The following is a description of a gene set: Human Gene Set: SP1_01 Genes having at least one occurrence of the motif GGGGCGGGGT in the regions spanning 4 kb centered on their transcription starting sites. This matches the SP1 transcription factor binding site V$SP1_01 (v7.4 TRANSFAC). species: Homo sapiens, and this is the list of marker genes: OLIG2, SERINC2, IDH3G, SLC7A10, KCND2, UBE2Z, ADAM10, BCL3, ANKMY2, LRRC4, UBE2F, DACH1, FBXL19, EPS15, GABARAP, TRPM4, UST (NCBI Gene Id 10090), HYAL2, CRYAB, RAB10, DES, DNMT3A, NSD3, CLPTM1, MAGED1, NDST2, FBRS, UNC13B, YRDC, TPM4, PALS1, SFXN2, CDC42SE1, BAHD1, UNC80, PPP2R3A, GGN, FBXW4, SEC63, PLCD1, ATXN1, GPR3, KPNB1, RPL7 (ribosomal protein L7), GGNBP2 (gametogenetin binding protein 2), NFE2L1, GRIPAP1, TSNAXIP1, HSPB2, EGLN2, STMN1, SLC44A1, NCOA2 (nuclear receptor coactivator 2), PIAS3, POU2F1, HNRNPA2B1, KLF16, VLDLR, NOL4, TAL1, KCNQ4 (NCBI Gene Id 9132), ATAT1, ZNF703, RDH10, FRS3, MEX3B, MYADM, HMGA1, OSBP, BHLHE41, SP4, GGA1, RING1, IRF2BP1 (interferon regulatory factor 2 binding protein 1), MAP3K6, ING2, SIX4, GJB6, EIF5A, RANBP10, GALE, NR2F2 (nuclear receptor subfamily 2 group F member 2), HS2ST1, TADA3 (transcriptional adaptor 3), KANK2, NXPH3, KCNE5, PPFIA2, SPATA6, PLEKHA8, PACS1, FXR2, SSR4, BCL2, CADM1, MARCKSL1, PPP1R21, GBF1 (NCBI Gene Id 8729), MTF1, NUBP2, NKX2-1 (NK2 homeobox 1), REM1, ZNF414, MTSS1, CEBPE, BCL9L, CAMKK1, BDNF, DNM3, AFF4, LRP1, SMG6, TCEAL1, GMIP (NCBI Gene Id 51291), BCL6B, ODR4, ZNF516-DT, ECE1, CCNE1, LRRC8D, KLK8, EPN2, ARID1A (AT-rich interaction domain 1A), SMARCA1, FEV, LARGE2, VEGFA, DLL4, CHST14, ROBO3, MTMR3 (NCBI Gene Id 8897), PUSL1, TPR, EDN3, NFKBIA, CLSTN1, SELENOF, VGLL2, SLITRK5, PKP3, TIGD4, NRAS, RNF24, PPRC1, SRSF7, DPY30, HMGN2, PAK1, HNRNPUL1, PI4KB, CHD6, ARPC4, ASCL2, FBXL19-AS1, B4GALT2, PORCN, TMEFF1, UTP18, CADM2, NFYC, TBX5, KIF1C, BZW2, CDCA7L, OSBPL9, BCL6, INCA1, CITED2, ZFP36, NAGK, SLC2A1 (solute carrier family 2 member 1, NCBI Gene Id 6513), ARAP1, HPN, HOXA3, KCNMA1, PRICKLE4, FAF1, BRMS1L, PDIK1L, C1orf54, KDM2A, RBBP4, GRIN2A, WNT5A, FKBP14, GFRA1, MLLT11, PCF11, GAP43 (NCBI Gene Id 2596), TCF12, PIP4K2B, MECOM, ASIC1, GAD1, SESN2, GLI1, PEX14, PIGV, ACLY, SYNCRIP, JADE2, CASQ1, VEZF1, MUC1, JMJD6, PODN, MNT, C1orf122, ARHGEF19, ARFIP1, GSC, COL12A1, WDFY2, ALOX12, KCND1, KDM3A, UBE2D3, PDLIM7, ZBTB8OS, PDE4C, BCL11B, CSRNP2, EDA, MN1, ARL3, SRR, PHF21A, CYP26B1, MAGED2, DNAH9, PTCH2, MSMB, DPAGT1, COL13A1, SNCB (synuclein beta), OAZ2, TBX2, SLITRK4, ZNF512 (NCBI Gene Id 84450)